Given this list of marker genes Il17re, Il17ra, Il27ra, Il17rd, Il17rb, Il17rc, here is a description of the gene set: Combining with any member of the interleukin-17 family of cytokines and transmitting the signal from one side of the membrane to the other to initiate a change in cell activity. studied in species Mus musculus Mouse Gene Set: GOMF_INTERLEUKIN_17_RECEPTOR_ACTIVITY